Given this list of marker genes SGCB, ACTB, IL10, CXCR4, CASP8, GSK3B, NFKB2, DFFA, BNIP2, MAPK1, CASP6, DFFB, TICAM1, CYCS, CAV1, ENDOG, IFNG, PIK3R1, BCL2, TLR3, DAG1, TLR5, HLA-DMA, EIF4G1, NOS1, CD55, CCND1, IL12A, EDN1, SGCA, BAX (NCBI Gene Id 581), ABL1, TNF, CASP9, RAC2, IL12B, AIF1, CCR5, TGFB1, CCR3, KRT8, ILK, CD40LG, SOCS1, DMD, JAK1, IL6, ITGB2, CHRAC1, CREB1, CASP7, NOD2, MICA, CXADR, MYH6, FYN, SGCD, CD4, IL2, PABPC1, RASA1, PYCARD, CASP3, CASP2, MAPK3, BID, AKT1, PTCRA, TLR4, PARP1, STAT1, CAAP1, LAMA2, SGCG, CASP1, RAC3, EIF4G2, CD80, ABL2, ITGAL, SRC, MMP9, STAT3, SOS1, BCL2L1, here is a description of the gene set: Acute viral myocarditis species: Homo sapiens Human Gene Set: WP_ACUTE_VIRAL_MYOCARDITIS